The following is a description of a gene set: Genes positively differentially expressed in cell type: Mast cell upon treatment with cytokine: IL-3 in mouse lymph nodes in vivo. from publication Cui A, Huang T, Li S, Ma A, Pérez JL, Sander C, Keskin DB, Wu CJ, Fraenkel E, Hacohen N (PMID 38057668) Mouse Gene Set: CUI_MAST_CELL_IL3_RESPONSE_UP Cytokines mediate cell-cell communication in the immune system and represent important therapeutic targets. A myriad of studies have highlighted their central role in immune function, yet we lack a global view of the cellular responses of each immune cell type to each cytokine. To address this gap, the authors created the Immune Dictionary, a compendium of single-cell transcriptomic profiles of more than 17 immune cell types in response to each of 86 cytokines (>1,400 cytokine-cell type combinations) in mouse lymph nodes in vivo. A cytokine-centric view of the dictionary revealed that most cytokines induce highly cell-type-specific responses. For example, the inflammatory cytokine interleukin-1β induces distinct gene programmes in almost every cell type. A cell-type-centric view of the dictionary identified more than 66 cytokine-driven cellular polarization states across immune cell types, including previously uncharacterized states such as an interleukin-18-induced polyfunctional natural killer cell state. species: Mus musculus, and this is the list of marker genes: Pim1, Lcp2, Socs1, Emb, Metrnl, Gpm6b, Bhlhe40, Slc7a8, Lilrb4b, Eif4a1, Letmd1, Enah (NCBI Gene Id 98642), Fdx1, Csf2rb2, Rab44, Serpina3g, Map3k11, Rnase6, Tph1 (tryptophan hydroxylase 1), Cnot6l, Slfn2, Klk8, Muc13, Stk39 (NCBI Gene Id 99416), Furin, Cdkn1a, Vim, Rprm, Nsf, Zfp120 (NCBI Gene Id 320490), Cltc, Pilra, Plcg1, Gab2, Polr2b, Ptpn2 (protein tyrosine phosphatase, non-receptor type 2), Tpsab1, Atp6ap2, Tgfb1, Top1, Cyp11a1, Fbxw7, Cish, Zfp53, Cd53